Given this list of marker genes Aff3, Aff1, Aff2, Eaf2, Eaf1, Aff4, here is a description of the gene set: Mouse Gene Set: GOCC_SUPER_ELONGATION_COMPLEX A transcription elongation factor complex that increases the overall rate of RNA polymerase II transcription elongation by suppressing transient polymerase pausing. At minimum, the complex contains a transcription factor of the ELL family, an EAF protein, and an AFF family protein or distant relative and most likely also P-TEFb and AF9 or ENL. The complex is conserved from yeast to humans. In Schizosaccharomyces pombe it contains Ell1, Eaf1, and Ebp1, but it is absent from S. cerevisiae. studied in species Mus musculus